Given this list of marker genes ANTXR1, GLYCTK, TGM4, RPL12, SEZ6, LRP11, APOA4, P3H2, GNAT2, PAX7, PAPPA2, SHC2, SYT6, LRFN3, B3GAT1, PLAAT1, MYRIP, RGS5, MIR326, GIMAP6, KCTD12 (NCBI Gene Id 80710), GPNMB, C1QA, RPL34, FZD8, USHBP1, CDKN2A, NACA, BTF3, FAU, APLN, CBFA2T3, PMM1, LY6G6E, SAMD12, FGF8, KRTAP3-1, BHMT2, NAA11, MAPK13, RCAN2, GUCA2B, OCA2, DMKN, GNGT1, XIRP1, FGF11, VPS13D, RPL11, MNS1, JPH4, MED8 (mediator complex subunit 8), PPP1R3E, CKB, RADIL, SCTR, PRKCSH, BDNF, NSG2, AHSG, OSR1, TBX20, PPM1J, EPHX2, LPIN1, RUNDC3B, EPS8L1, HGSNAT, OSR2, JMJD6, CABP1, NKX3-2, CD93, WNT5B, GPR179, RNASE1, UNC45B, GPR3, OASL, EMX2, ITGAX, NDUFS5, HSH2D, MYO7A, ODAD1, GIMAP3P, SALL4, PROCR, KLHDC4, KCNC1, DPCD, KCNMB4, CCN5, DLGAP1, SOX3, DAPK1, CH25H, ZFHX3, MANF, CLDN4 (NCBI Gene Id 1364), FITM1, ABHD14B, SH3BGRL3 (SH3 domain binding glutamate rich protein like 3), EVX1, HSPA1A, TMEM144, DIP2C (disco interacting protein 2 homolog C), ASB5, TMEM200B, P3H3, BTG2, RPS4Y2, SDK1, PCDHB12, COMMD7 (COMM domain containing 7), PNO1 (partner of NOB1 homolog), EIF3K (eukaryotic translation initiation factor 3 subunit K), LRRTM1 (leucine rich repeat transmembrane neuronal 1), RSAD1, STMN1, SASH3, COL14A1, RASL10A, RPL23A, FOXI2, TMEM132D, NEU4, P2RY2, SEL1L3, GIMAP4 (NCBI Gene Id 55303), PTPRU, MTSS2, SV2B, LEPROTL1, CKS1B, CPSF3, PRSS36, FGFR4, TTC7A, IGSF11, COL11A1, RGS6, CYP11B2, PHLDB1, here is a description of the gene set: studied in species Homo sapiens Human Gene Set: GSE10147_IL3_VS_IL3_AND_HIVP17_STIM_PDC_DN Genes down-regulated in plasmacytoid dendritic cells: IL3 versus IL3 and the HIV matrix protein p17. from publication Fiorentini S, Riboldi E, Facchetti F, Avolio M, Fabbri M, Tosti G, Becker PD, Guzman CA, Sozzani S, Caruso A (PMID 18310327) We used microarrays to detail the global program of gene expression underlying the effect of p17 on human plasmacytoid dendritic cells and was compared to CpG profile.